The following is a description of a gene set: Human Gene Set: WP_THYROXINE_THYROID_HORMONE_PRODUCTION Thyroxine (thyroid hormone) production studied in species Homo sapiens, and this is the list of marker genes: ANO1, SLC5A5, ELK1, TG, PRKAA1, SLC26A6, TRH, PRKCA, DUOX1, DUOX2, MAP2K2, ACY1, TSHR, CGA, MAPK1, CLCN5, MAP2K1, RAF1, NFKB1, TPO, RAP1A, MAPK3, PRKAA2, CREB1, RAP1B